Given this list of marker genes MMP21, MMP3, MMP25, MMP20, TIMP4, MMP2, MMP14, TIMP2, BSG, MMP16, MMP27, MMP11, TNF, MMP26, MMP7, TIMP3, MMP12, TCF20, TIMP1, MMP1 (NCBI Gene Id 4312), MMP23B, MMP9, MMP13, MMP17, MMP10, MMP15, MMP19, MMP8, MMP24, MMP28, here is a description of the gene set: Matrix metalloproteinases species: Homo sapiens Human Gene Set: WP_MATRIX_METALLOPROTEINASES